The following is a description of a gene set: studied in species Mus musculus Enables the transfer of organic anions from one side of a membrane to the other, in a sodium independent manner. Mouse Gene Set: GOMF_SODIUM_INDEPENDENT_ORGANIC_ANION_TRANSMEMBRANE_TRANSPORTER_ACTIVITY, and this is the list of marker genes: Slco1a4, Slc22a30, Slc22a19, Slco3a1, Slco6d1, Slc22a29, Slc22a26, Slc22a27, Slco1c1, Slco1a1, Slco2a1, Slco2b1, Slco4a1, Slco1b2, Slc22a7, Slco5a1, Slco1a7, Slco6c1 (NCBI Gene Id 96889), Slc22a28, Slco1a5, Slc22a6, Slco1a6, Slco1a8, Slco4c1